Given this list of marker genes DNER, KCTD10 (potassium channel tetramerization domain containing 10), CUL3, MEGF10, SNED1, DLL4, DLL1, CHAC1, NCOR2, JAG2, TCIM, SNW1, JAG1, NOTCH1, ADAM17, NOTCH4, ATRNL1, DTX1 (deltex E3 ubiquitin ligase 1), HIF1AN, GALNT11, NOTCH2NLB, DLL3, NOTCH2NLA, AAK1, DLK2, CCN3, here is a description of the gene set: Human Gene Set: GOMF_NOTCH_BINDING species: Homo sapiens Binding to a Notch (N) protein, a surface receptor.